Given this list of marker genes ATP12A, IL1A, SLC8A1, SLC9A1, ATP1A1, SCNN1B, SCNN1A, TMPRSS3, ATP1A4, SCNN1G, ATP1B2, ATP1A3 (NCBI Gene Id 95633), SLC12A2, FXYD2, ATP1A2, SLC1A3, UMOD, ATP1B1, ATP4A, ATP1B3, ATP4B, SCNN1D, here is a description of the gene set: A homeostatic process involved in the maintenance of a steady state level of sodium ions within a cell. studied in species Homo sapiens Human Gene Set: GOBP_INTRACELLULAR_SODIUM_ION_HOMEOSTASIS